Given this list of marker genes Xrcc5, Mir126a, Lmbr1l, Mettl3, Mir125b-2, Zfp36, Meox1, Tcf15, N4bp2l2, Hoxb4, Tmsb4x, Nfe2l2, Ext1, Trp53, Mllt3 (myeloid/lymphoid or mixed-lineage leukemia; translocated to, 3), Foxc1, Mir542, Eif2ak2, Ercc2, Ythdf2, Kat5, Mir155, Fancb, Med1, Srf (serum response factor), Prkdc, Fbxo21, Mir125b-1, Hspa9, Sfrp1, Batf, Terc, Cdk6, Chd2, Sh2b3, Mir130a, Ufl1, Tal1, Mir193b, Mirlet7e, Sp7, Ap2a2, Mir181c, Bcl2, Setd1a, Pus7, Mir99a, here is a description of the gene set: The process in which a relatively unspecialized cell acquires specialized features of a hematopoietic stem cell. A stem cell is a cell that retains the ability to divide and proliferate throughout life to provide progenitor cells that can differentiate into specialized cells. studied in species Mus musculus Mouse Gene Set: GOBP_HEMATOPOIETIC_STEM_CELL_DIFFERENTIATION